Given this list of marker genes ARRDC3, CDKN2A, FEM1A, ABL1, FEM1B, BMI1, MAD2L2, ARRDC4 (NCBI Gene Id 91947), USP44, RPS7, CDC14B, RPS2, CDC20, BAG5, PLK1, MAGEA2B, FZR1, RPL11, UBE2C, RPL5, RPL23, DTX3L, MAGEC2 (MAGE family member C2), MAD2L1, MAGEA2, SKP1, FBXO5, UBE2S, BTRC, here is a description of the gene set: Any process that modulates the frequency, rate or extent of ubiquitin transferase activity. Human Gene Set: GOBP_REGULATION_OF_UBIQUITIN_PROTEIN_TRANSFERASE_ACTIVITY species: Homo sapiens